The following is a description of a gene set: studied in species Mus musculus Combining with an N-formyl peptide to initiate a change in cell activity. Mouse Gene Set: GOMF_N_FORMYL_PEPTIDE_RECEPTOR_ACTIVITY, and this is the list of marker genes: Fpr-rs6, Fpr3, Fpr-rs3, Fpr1, Fpr2, Fpr-rs7, Fpr-rs4